The following is a description of a gene set: Mouse Gene Set: REACTOME_G1_S_DNA_DAMAGE_CHECKPOINTS G1/S DNA Damage Checkpoints species: Mus musculus, and this is the list of marker genes: Psmd13, Psmd7, Psmb1, Psma3, Psmc3, Mdm2, Ccna2, Cdk2, Zfp385a (zinc finger protein 385A), Psmd6 (proteasome (prosome, macropain) 26S subunit, non-ATPase, 6), Mdm4, Ccne2, Psma2, Psmc4, Ubb, Phf20, Psma7, Cdc25a, Uba52, Psmb4, Cop1, Psma4, Psmd1, Ubc, Psmb2, Cdkn1a, Adrm1, Ccna1, Psmd14, Psmb6, Psmb5 (proteasome (prosome, macropain) subunit, beta type 5), Psmd12, Psmb7, Chek1, Rps27a, Psma1, Chek2, Ccne1, Uba52rt, Cdkn1b, Psmc5, Psmd3, Psmb3, Cdkn1c, Psma6, Trp53, Psmc1, Psmd2, Atm (NCBI Gene Id 77416), Psmd8, Psmd11, Psma5, Psmc6 (NCBI Gene Id 67089), Psmc2